Given this list of marker genes RPL13, PTCD3, PTH1R, ORC4 (origin recognition complex subunit 4), SCNN1G, SLC39A13, ORC1, DVL3, HCCS, NDUFB11 (NADH:ubiquinone oxidoreductase subunit B11), CAMK2G, CENPT, ANTXR1, ESCO2, DPP9, RMRP, INPPL1, MBTPS2, CTSA, LBR, SDHB, COL2A1, NEPRO, CENPJ, DOCK3, NIN, GHR, COL9A2, ERCC6, DYM, IDS, RTTN, PPP1R15B, GUSB, SDHD, COL9A3, DHCR24, ERCC4, SMAD4, FGFR3 (NCBI Gene Id 55546), DLX5, NSMCE2, DVL1, HADH, CASK, RECQL4, SHOX, CHD6, PCYT1A, TCTN3, COL10A1, COL11A1, PYCR1, RNU4ATAC, PDE4D, COX7B, EVC2, FBN1, STAT5B, FAM111A, RUNX2, GHRHR, WNT5A, HOXD13, TRMT10A, AMER1, CANT1, DDRGK1, TBCE (tubulin folding cofactor E), BRF1, ADAMTS2, LARP7, DRG1, ARSL, XYLT1, ANTXR2, IGF1R, SLC26A2, PCGF2, CTNNB1, SGMS2, GORAB, SMARCA2, OBSL1, GLB1, ACAN, BRAF, TRIP11, CDC6, KMT2D, STRA6, TKT, MIA3, SALL4, SDHA, MATN3, CSGALNACT1, FGD1, GH1, SCNN1A, CRIPT (NCBI Gene Id 9419), B3GALT6 (NCBI Gene Id 126792), PNPLA6, EPRS1, EVC, SON, HSPG2, LYSET, SDHAF1, COL1A1 (NCBI Gene Id 4970), CDC45, LTBP3, CKAP2L, CHST11, PEX7, PIEZO2, ORC6, ZBTB18, HSPA9, TRPV4, GMNN, COMP, COL1A2, FGFR1, PTDSS1, SIL1, ATR, ATP11A, KIF11, SCNN1B, MESP2, AGO1, DNMT3A, ERCC8, TBX6, KDM6A, DCC, FZD2, PIK3R1, ROBO3, MAP3K7 (mitogen-activated protein kinase kinase kinase 7), POLE, HHAT, ZMYM3, GNPNAT1, CDT1, ADAMTS10, DLL3, FLNB, ADAMTSL2, SELENOI, NPR2, KAT6B, here is a description of the gene set: Human Gene Set: HP_PROPORTIONATE_SHORT_STATURE Proportionate short stature species: Homo sapiens A kind of short stature in which different regions of the body are shortened to a comparable extent.